The following is a description of a gene set: Human Gene Set: GOBP_NATURAL_KILLER_CELL_ACTIVATION_INVOLVED_IN_IMMUNE_RESPONSE species: Homo sapiens The change in morphology and behavior of a natural killer cell resulting from exposure a cytokine, chemokine, cellular ligand, or soluble factor, leading to the initiation or perpetuation of an immune response., and this is the list of marker genes: VAMP7, AP1G1, IFNA17, FCGR3A, KLRF2, HLA-F, CD244, UNC13D, IFNA4, RAB27A, IFNA10, IFNA1, IFNA8, IFNA16, IFNE, IFNK (NCBI Gene Id 95265), CORO1A, IFNA21, IFNW1, VAMP2, IFNA5, IFNA2, IFNA6, IFNB1, IFNA7, NKG7, IL12B, KLRC2, LAMP1, IFNA14, CD160